Given this list of marker genes PEX5, COL2A1, EIF2AK3, SEC24D, SEC23A, ZBTB20, RPS6KA3, SOX9, CTSK, NANS (NCBI Gene Id 54187), here is a description of the gene set: species: Homo sapiens Decreased width of the wing (or ala) of the ilium (which is the large expanded portion which bounds the greater pelvis laterally). Narrow iliac wing Human Gene Set: HP_NARROW_ILIAC_WING